The following is a description of a gene set: from publication Wei G, Wei L, Zhu J, Zang C, Hu-Li J, Yao Z, Cui K, Kanno Y, Roh TY, Watford WT, Schones DE, Peng W, Sun HW, Paul WE, O'Shea JJ, Zhao K (PMID 19144320) Multipotential naïve CD4+ T cells differentiate into distinct lineages including T helper 1 (Th1), Th2, Th17, and inducible T regulatory (iTreg) cells. The remarkable diversity of CD4+ T cells begs the question whether the observed changes reflect terminal differentiation with heritable epigenetic modifications or plasticity in T cell responses. We generated genome-wide histone H3 lysine 4 (H3K4) and lysine 27 (H3K27) trimethylation maps in naïve, Th1, Th2, Th17, iTreg, and natural (n)Treg cells. We found that although modifications of signature cytokine genes (Ifng, Il4, and Il17) partially conform to the expectation of lineage commitment, critical transcription factors such as Tbx21 exhibit a broad spectrum of epigenetic states, consistent with our demonstration of T-bet and IFN-gamma induction in nTreg cells. Our data suggest an epigenetic mechanism underlying the specificity and plasticity of effector and regulatory T cells and also provide a framework for understanding complexity of CD4+ T helper cell differentiation. Human Gene Set: GSE14308_TH2_VS_TH1_UP Genes up-regulated in comparison of Th2 cells versus Th1 cells. species: Homo sapiens, and this is the list of marker genes: ANKRD46, ZNF808, ERCC5, WASHC5, NUP35, ATP8B2, IL6ST, ZDHHC5, TARS1, INHBA, ANXA4, CDC20, WDR26, CAB39L, CHCHD6, MMGT1, DTNBP1, TMEM86B, ANAPC10, PLCL1, CASP6, AUH, PPP6C, CORO7, TP53INP2, RBMX, HS6ST1, TLE3, SRXN1, ETV5 (NCBI Gene Id 2119), MLKL, RYK, CALR, ALDH9A1, PTGER2, ARPC2, CCDC126, TMEM135, PRRC1 (proline rich coiled-coil 1), VEGFA, FASTKD2 (FAST kinase domains 2), LSM1, MAML1, SCAMP2, MON2 (NCBI Gene Id 23041), GCLM, FERRY3 (FERRY endosomal RAB5 effector complex subunit 3), CENPN, SLC25A39, MINDY1, SIK3, PSPH, C8orf76, RCL1, NTAQ1, PLXNB3, GPR174, TMEM131, SYNJ1, SPRED1, SLC10A3, TXN, ZCRB1, CDK13, ATP6AP1, INKA1, ERGIC1, PFN1, WDR81, ALDH18A1, CASS4, FBXO10, GPAT3, IL9R (NCBI Gene Id 3581), FUCA1, CLPTM1L, CHURC1, GPAA1, EIF1, PPP1R18, HNRNPL (heterogeneous nuclear ribonucleoprotein L), PRKCI (protein kinase C iota), TBC1D21, GLB1, WDR83OS, EMSY, ADARB1, HUWE1, PDE6D, ENTPD3, SH3RF1, GTF2A1, PSMA3, SLCO1C1, HES1, TLK1, DTNB, CYB5R3, PPP6R2, USP6NL, WDR11, COL4A1, TRAF2, POLR2E, DMAC2L, EIF5A2, CALU, ATP2B1, SMARCD1, HNRNPH2, BCAT2, SOX9, POC5, RBMS2, TDRD7, DIAPH3, MPC1, ISCU, UNC13A, BCAR3, PEX16, THY1, BANF1, GAK, SRSF9, CRTAP, RCC2, CARHSP1, HTR1B, APC, CHPF2, NDUFAF4, VAT1, SACS, WTAP, SLX4, ARHGAP18, FNIP2, PRKRA, EIF4E, CUL1, TMOD4, PLAA, OSGEP, PPP5C, ANLN (anillin, actin binding protein), CRIP2, PAPSS1, PDP1 (pyruvate dehydrogenase phosphatase catalytic subunit 1), NEFH, CDH6, ZPBP2, BSG (NCBI Gene Id 682), MFSD12, ASCC3, CDC42BPG, KCTD6, GNRHR, UXS1 (NCBI Gene Id 80146), DNAJB12, ORMDL2, CAPN8, HOOK1, ALS2, DNAL1, P2RY10, UAP1L1, POMT2, CPQ, MT1E, HDGF, RNF215, HMGN3, MLEC, BOP1, ST8SIA2, GRIN2D, VLDLR, AP1S1, TMEM30A, FASTKD3, TAOK3 (TAO kinase 3), PBX3, RNF19A, EHBP1, DDX19A, CFAP251, CAMSAP3, CD99, DGCR6, NPRL3, FMC1, NUP93, ROCK1, TAPT1, PGK2, ZNF638, PAFAH1B2, ACTN4